Given this list of marker genes ELOVL5, ELOVL3, HACD2, ABCD1, HACD1, ELOVL2, HACD4, ELOVL4, ELOVL1, TECR, HSD17B12, ELOVL6, ELOVL7, HACD3, here is a description of the gene set: The elongation of a fatty acid chain by the sequential addition of two-carbon units. species: Homo sapiens Human Gene Set: GOBP_FATTY_ACID_ELONGATION